The following is a description of a gene set: Human Gene Set: WP_IL7_SIGNALING IL7 signaling studied in species Homo sapiens, and this is the list of marker genes: STAT5B, BAD, PTK2B, AKT1, JAK3, JAK1 (Janus kinase 1), PIK3R2, GSK3B, CDKN1B, MAPK1, BCL2L1, IL2RA, FYN, MAP2K2, PIK3R1, STAT3, MYC, IL7R, STAT1, MAPK3, CCND1, MAP2K1, STAT5A, IL2RG, IL7